The following is a description of a gene set: Any process, acting in the presynapse that results in modulation of chemical synaptic transmission. species: Mus musculus Mouse Gene Set: GOBP_PRESYNAPTIC_MODULATION_OF_CHEMICAL_SYNAPTIC_TRANSMISSION, and this is the list of marker genes: Nrn1, Fxr1, Tprg1l, Chrna6, Adrb2, Htr1b, Adra2a, Grm4, Gipc1, Fbxl20, Adora2b, Bace1, Drd1, Ngfr, Chrna4 (cholinergic receptor, nicotinic, alpha polypeptide 4), Htr2a, Hip1, Grik2, Fmr1, Grm7, Nrxn2, Htr7, Adra1a, Lamp5, Nr3c2, Prkca, Oprm1, Cacna1d, Chrm2, P2rx7, Gsk3b, Grin3a, Ywhah, Chrnb3, Grm2, Git1, Chrna7, Syt12, Grm8, Drd2, Git2, Chrnb2 (cholinergic receptor nicotinic beta 2 subunit), Prkce, Apba2, Grik1, Pfn2, Rab3a, Chrna5, Cyth1, Chrd, Fxr2 (NCBI Gene Id 23879), Glra3, Adcy1, Drd4, Dgki, Adora3, Apba1, Unc13b, Nog, Myo6, Prkcg, Chrna3 (NCBI Gene Id 235388), Htr1a, Nrxn3, Prkcb, Adora2a